Given this list of marker genes Gm7701, Gm15972, Gm33674 (NCBI Gene Id 102636671), Gm6378, Asxl3, Gm10269, Trappc8, Celf4, Gm7847, Gm46611, Gm18085, 4930578E11Rik (NCBI Gene Id 78058), B4galt6, Tpgs2, Gm7788, Gm18089, Dsg3, Mapre2, Gm33228, Zscan30, Mep1b, Gm4837, 4930426D05Rik, Gm23674, Garem1, Mif-ps10, Rnf138, Rprd1a, Mir6360, Rpl19-ps7, Gm24246, Gm34658, Dsg1c, Gm23207, Zfp397, Ccdc178, Gm3227, Gm16090, 2700062C07Rik, Ino80c (INO80 complex subunit C), 4930527G23Rik, Gm47898, Dsg1b, Galnt1, Zfp24, Dsc1, AW554918, Gm33948, Gm34743, Gm22495, Rnf125, Klhl14 (NCBI Gene Id 73999), Gm7729, Elp2, Gm5688, Gm6643, Gm7758, Slc39a6, Gm38410, Dsc3, Gm9955, Gm7874, Fhod3, Tpi-rs10, Dsg4, BC051408, Ttr, Dtna, Mir187, Dsg2, Dsc2, Gm7720, Gm5064, Dsg1a, Nol4, 0710001A04Rik, Mocos, Zfp35, here is a description of the gene set: species: Mus musculus Mouse Gene Set: chr18A2